Given this list of marker genes Fpr-rs6, Fpr-rs7, C3ar1, Fpr-rs4 (NCBI Gene Id 14291), Cr2, Gpr33, Fpr3, C5ar2, Cr1l, Fpr-rs3, Fpr1, Cmklr1, C5ar1, Fpr2, here is a description of the gene set: species: Mus musculus Mouse Gene Set: GOMF_COMPLEMENT_RECEPTOR_ACTIVITY Combining with any component or product of the complement cascade and transmitting the signal from one side of the membrane to the other to initiate a change in cell activity.